Given this list of marker genes ITGA1, GSK3B, AMMECR1L, LRMDA (leucine rich melanocyte differentiation associated), LCP2, SLC38A11, BMPR2, RAG2, IL11RA (interleukin 11 receptor subunit alpha), PPP1R10, MMP14, NKAIN3, PTCHD1, FBXL19-AS1, EBF2, DCX, HOXB13, UBE2D3, NKX2-3, BTBD3, ADAM11, KLF5, NSG2, C10orf71, CBFA2T2, SNHG29, CREB5, NCDN, LMO4, TC2N, WDR5B, SOX5, RIT2, SERTAD4, VIP, STAT5B, FAM91A1, PAK1IP1, ZBTB18, GGT6, ST13P4, POLA1, PCF11, TAT, TSHZ2, ANKRD17, ALPK2, TFDP2, NRG1 (NCBI Gene Id 653104), RUNX1T1, NOG, XKRX, DMBT1, HOXB6, GPR173, CDK2, TENT5A, TENM1, JPH1, SSTR1, S100A10, LMO2, C12orf50, ADCY6, EDN1 (endothelin 1), PHYHIP, PWWP2B, EIF4G1, WRN (WRN RecQ like helicase), HAS2, RTN2, ELK4, CALD1, ARMCX1, XCR1, KANSL3, ARHGAP6, PIANP, CTDSPL2, MECOM, ATP6V1G3, ACAD11, AGR3, SLC15A2, DLX5, SAG, STC1, PLP2 (NCBI Gene Id 5355), ELMO1, GLRA1, USP49, ZFHX3, DACT1, CNTLN, COL12A1, C1orf122, DMTN, SLIT3, IER5L (NCBI Gene Id 445576), PURG, HOXA6, SEPTIN4, MAMDC2, GDF7, BBS12, WNT2B, GPR19, RAB6A, OFCC1, C2CD2L, ELP4, GRHL3, COMMD1, FZD1, DMD, LONRF3, LPL, GPR37L1, UBE2E1, LEMD1, VWF, NT5C3B, FER1L6-AS1, BAMBI, ZDHHC1, C7 (complement component 7), IL1RAPL1, RPS6KL1, KLHL10, STMN1, RALYL, BCL11A, PI16, LGI1, PURA, SLC12A8, NDUFA1 (NCBI Gene Id 4694), NUP210L, SUPT4H1, COL27A1, LBHD1, SNCA, UTS2, LIX1L, TAL2, LINC01465, BEST2, DDIT4L, RRP36, WNT9A, ASH1L, DUSP5, EML4, TMPRSS11A, PELO, SELL, STX18, CEP44, CALM1, NUB1, NYX, LMO3 (NCBI Gene Id 55885), PAN2 (poly(A) specific ribonuclease subunit PAN2), TMPO, YRDC, DPYSL2, WNT8B, LAPTM4A, ELAVL4 (NCBI Gene Id 1996), GRIN2D (glutamate ionotropic receptor NMDA type subunit 2D), DCHS2, ATXN1, STAU1, MYH6, ANGPTL6, RWDD1 (RWD domain containing 1), MTF2, ZFP36L1, BHLHE40, TAF10, C22orf31, UBA5, EYA1, NUBP2, MAB21L2, SLC25A12, MYT1, CDH10, MYH4, PPP2R2C, ITGB1BP2, ACTG2, CXXC5, CDC42EP3, SV2A, RBMS3, ANK1, EPHB6, USP51, RAB10, MBNL1, PTMS, ELAVL2, FBXL19, SPOP, CDK2AP1, FBXL14, VWA5B1, ZNF516-DT, TNKS1BP1, RSPO2, ZNF462, NEUROD6, DVL3, HRH3, FERD3L, CPLANE1, HSD11B1, POU2F1, TMEM204, LHX1, SYT16, STAG1, MRTFA (NCBI Gene Id 89880), ECHDC2, SLN, FBXO8 (F-box protein 8), OGDHL, DLC1, PHF3, ABLIM1, ACKR1, LRRTM4, STK36, TMCC1, TMEM132E, NEUROG2, RCOR2, NGEF, EP300, MYL1, PTK6, TMEM132E-DT (TMEM132E divergent transcript), FBXW4, CELF3, EMID1, TPGS1, NR2F2, CLVS1, IMMP1L, MRPS18B, HYPK, MEF2C, GNL3LP1, SBSPON (NCBI Gene Id 157869), CLC, CCDC88A, CTNNA3, DCDC1, ZNF366, ODAPH, NRK, LY86, VGF, HOXC6, RBM33, KDM3B, RNF113A, PDZD9, RNF25 (ring finger protein 25), LARP4, PMEL, FAM241A, ZSWIM8, CREB3L2, LIX1, MAPK3, MUSK, GOLGA7, TGFBR1, RNF112, NFATC2, PRKCH (protein kinase C eta), PPP6R3 (protein phosphatase 6 regulatory subunit 3), here is a description of the gene set: Human Gene Set: HAND1E47_01 Genes having at least one occurrence of the motif NNNNGNRTCTGGMWTT in the regions spanning 4 kb centered on their transcription starting sites. This matches the HAND1 transcription factor binding site V$HAND1E47_01 (v7.4 TRANSFAC). species: Homo sapiens